The following is a description of a gene set: Mouse Gene Set: REACTOME_INTERCONVERSION_OF_NUCLEOTIDE_DI_AND_TRIPHOSPHATES studied in species Mus musculus Interconversion of nucleotide di- and triphosphates, and this is the list of marker genes: Ak1, Nme3, Ak9, Ak6, Ak8, Txnrd1 (thioredoxin reductase 1), Cmpk1, Nme2, Guk1, Dctd (dCMP deaminase), Dut, Nme4, Ak7, Ctps1 (cytidine 5'-triphosphate synthase 1), Ak4, Ak5, Nme1, Ak2, Rrm2b, Ctps2, Tyms, Gsr, Glrx, Txn1, Rrm1, Dtymk, Rrm2, Nudt13